The following is a description of a gene set: from publication Szanto A, Balint BL, Nagy ZS, Barta E, Dezso B, Pap A, Szeles L, Poliska S, Oros M, Evans RM, Barak Y, Schwabe J, Nagy L (PMID 21093321) Conditional macrophage-specific PPARg knockout mice were generated on C57Bl/6 background by breeding PPARg fl/- (one allele is floxed, the other is null) and lysozyme Cre transgenic mice. PPARg and IL-4 signaling was analyzed on bone marrow-derived macrophages. Bone marrow of 3 mice per group was isolated and differentiated to macrophages with M-CSF (20 ng/ml). 20 ng/ml IL-4 was used to induce alternative macrophage activation and 1 uM Rosiglitazone (RSG) was used to activate PPARg. From each mouse 4 samples were generated: 1. M-CSF, 2. M-CSF+RSG, 3. IL-4 and 4. IL-4+RSG. All compounds were added throughout the whole differentiation process, and fresh media was added every other day. Control cells were treated with vehicle (DMSO:ethanol). After 10 days, RNA was isolated and gene expression profiles were analyzed using Mouse Genome 430 2.0 microarrays from Affymetrix. studied in species Homo sapiens Genes down-regulated in bone marrow-derived macrophages with PPARG knockout treated with IL4: control versus rosiglitazone. Human Gene Set: GSE25123_IL4_VS_IL4_AND_ROSIGLITAZONE_STIM_PPARG_KO_MACROPHAGE_DAY10_DN, and this is the list of marker genes: TAC1, ESR2, ADPGK, SORCS2, EMP1, MLX (MAX dimerization protein MLX), SLCO4A1, RUSC2, NDRG3, SLAMF9, CXCL8, NPFFR1, TUT7, PGM1 (phosphoglucomutase 1), ENTPD1 (NCBI Gene Id 953), WNT5A, FNDC3B, CD109, SLC25A53, ACAP1, SSBP2, PGAP1 (NCBI Gene Id 80055), GBE1, GSC, ETS2, COL7A1, SLC44A2, PGK1, TBC1D10C, PKD2, UBA6, B3GALT6, CYB5R3, OLR1, CLN8, KIF3A, PPP1R3B, PRRG1, CXCL2, IL2RA, MIR21, MIR23AHG, FCER1G, IRF2BPL, NUMB, TIMP1, TNFRSF4, FLNB, SLC11A2, CAVIN1, CA2, AK4, TMEM187, PITPNM1, KLHDC7B, RAC2, NUP153, CA3, CSGALNACT2, C15orf48, FOS, SLC25A37, TM4SF1 (NCBI Gene Id 9004), CYTIP, IL1A, VASP, CLDND1, RAB24, CDC14C, LY6E, CCL5, SYNGR3, FAM43A, PRR16, SEMA4D, FCGR2A, EMP2, LYZ, SELL, PDS5B, EMP3, VMP1, RUBCNL, GNG8, DGAT2, KLF2, SPP1, SPMIP8, NT5E (NCBI Gene Id 4907), ZNF90, CLEC2D (C-type lectin domain family 2 member D), AMN1, AFF1, GALNT6, TMEM45A, AGK, FXYD2, SHB, EREG, RTTN, ZC3H12A, SGSH, NPDC1, CXCL3, HCFC1R1, TUBA4A, TREM1, SEMA4C, C18orf54 (NCBI Gene Id 162681), EVI2B, SLC25A16, AIF1, MRPS6, ERRFI1, TMSB15B, GPR84, TNF, ITGB1BP2, PHLDA1, SLC5A3, PTGS2, LINC00205 (NCBI Gene Id 652360), PIK3C2A, SHISA5, SLC43A3, OAZ1, MAOA, PPP2R5B, SUN2, TPI1, PIK3C2B (NCBI Gene Id 5287), PTPRC, NUP62, IL36G, RNF213-AS1, EVI2A, NCF2, ADGRE2, PLA2G4A, SQLE, TNFRSF21, CCL20, SLC44A1, SLC16A1-AS1, SRSF9, NACAD, TNFRSF10D, RFLNB, RGCC, TMEM154, PTPRE, MAFK (MAF bZIP transcription factor K), IL1RN, CD53, PGAM1, SEC24A, MS4A4A, TNNT1 (troponin T1, slow skeletal type), PFKFB3, TRPM2, TRIM25, OSBPL8, TMED8, FBXO2, NME4, TAB2, CXCL5, PLK3, TNFRSF18, DDIT4L, PAQR5, POU5F1P4, MAP2K3, IL1B, MAP3K13, TSHZ3, FXYD6, MIR155HG, CD99P1, CD63, C12orf75, POM121, TSPAN14, AATBC (NCBI Gene Id 284837), GNB3, LDHA, CYB561D2 (NCBI Gene Id 11068), LCP2, PPIF, NEDD4L, TLR2, PIK3AP1, ITPR3, OSGIN2, TUSC3